Given this list of marker genes Tyk2, Il15, Il23a, Stat5b, Lep, Il12b, Ptpn22, Il18, Jak2, Flt3l, Cd244a, H2-T23, here is a description of the gene set: Any process that modulates the frequency, rate or extent of natural killer cell proliferation. Mouse Gene Set: GOBP_REGULATION_OF_NATURAL_KILLER_CELL_PROLIFERATION studied in species Mus musculus